The following is a description of a gene set: Gene expression analysis of freshly isolated CD14+ human monocytes and monocytes cultured in the presence or absence of interferon (IFN) -gamma for 24 h and then stimulated with Pam3Cys, a Toll-like receptor (TLR) 2 ligand, for 6 h. Results provide insight into mechanisms by which IFN-gamma reprograms early macrophage differentiation and subsequent response to TLR ligands. from publication Hu X, Chung AY, Wu I, Foldi J, Chen J, Ji JD, Tateya T, Kang YJ, Han J, Gessler M, Kageyama R, Ivashkiv LB (PMID 18976936) Genes down-regulated in comparison of macrophages cultured with M-CSF versus macrophages cultured with M-CSF and Pam3Cyc. Human Gene Set: GSE11864_CSF1_VS_CSF1_PAM3CYS_IN_MAC_DN species: Homo sapiens, and this is the list of marker genes: AARS1, FARSB, THRB, ABL2, MIR9-1HG, TMUB1, SF3B2, MAGI2-AS3, TBC1D1 (NCBI Gene Id 401125), SNRPD1, UGCG, RCAN1, SLC35F5, GBP1, ORMDL2, CHRNA10, CASP7, DHX37, THOP1, LSS, EPB41L5 (NCBI Gene Id 80242), CD83, FFAR3, PSMC1, MAPKAPK2, SLC13A2, PSME3, HIVEP1, MIER3, HLX, SEMA3E, ETS1, TAF1A, WIZ, CRISP2, EXOSC6, GNL2, DCAF7, TRIM61, CRYGA, FBXL19, EIF2A, CD300LD-AS1, PANX1, PLEKHO2, HCP5B, PPP1R27, COCH, NIFK, DAXX, SLAMF7, MRPL3, ALYREF, PRCC, BRPF3, POLD2 (DNA polymerase delta 2, accessory subunit), NUS1P3, ALDH1L1, EMC6, TRIM13, SEC61B, SLC1A3, POLR3D, DTX4, ZNF81, SRCIN1, GTF2A1L, NABP1, SCGN, SECISBP2, CHORDC1, NOL6, RHO, CRY1, RAD23A, UBE2O, IFNA16, MTA2, PTPN12, EN2 (engrailed homeobox 2), PIK3AP1 (phosphoinositide-3-kinase adaptor protein 1), P2RX7, SEMA3C (NCBI Gene Id 222200), NOC2L, C1orf198, SEC13, HOXD-AS2, IGFBP4, BATF3, MCCC2, SMURF1, MOK, ANXA7, GFPT2, RAB12, MRPL52, IMPDH2, EVA1A, GAL3ST2 (galactose-3-O-sulfotransferase 2), SOS1, PMM2, YBX3, HSPA13, NUP88, ZC3H15, ARHGEF19, ZC3H10 (NCBI Gene Id 84872), GOLT1A, PDCD1LG2, USP42, HIVEP3, KCNMB1, DCUN1D5, EIF1, GLA, TRAF7, FIGN, FAM110B, PDIA5, EIF4A1, GK3, DNAH12, TFDP1, PRPF19, LITATS1, LINC01085, NFE2L1, DOCK4, USP16, FOSL2, SZRD1, RAD23B (NCBI Gene Id 5887), CCRL2, BIRC3, TOMM70, OGN, SDF2, ASAP2, MED17, STPG1, PEDS1, PPA1, UFM1, IL6-AS1, USP47, PRXL2C, FAT2, PLAT, GPR107, SESN2, RCC2, RNF19B, USP14, CRIM1, MTHFS, RAB21, HMGN2P46, LYN, ENSG00000268472, NUP62, ARL8B, RPS16P5, LMNB1, S1PR5, C1QTNF1, NECAP1 (NECAP endocytosis associated 1), UPB1, GEMIN4, GAR1, PLGRKT, B4GALNT2, TEAD1, ACSL4, PCDH11X, IPO4 (NCBI Gene Id 79711), ZNF335, PEX7, YWHAH-AS1, TRA2A, NUP93, EDEM1, CYP2F1, ARFRP1, MPV17L2, PIP5K1C, BCL9, NR4A3, PPIF, URB1, MUCL1, MT1F (metallothionein 1F), TFAP2A, ANKRD12